Given this list of marker genes RNF145, CREBL2, SIX3, NEDD9, RORA, HMGCS1, ESR1, MAP3K1, CDK19, GPR158, KCNJ2, MBOAT2, PDE4D, CCDC88A, MAP7D1, TNFAIP3, ZCCHC3, PATJ, PHC3, TBPL1, PRSS12, TRPC4, HIF1A, PNLIPRP3, ZFP62, DIP2C, BBX, DIRAS2, RAB5A, PTGFRN, AGFG1, ADD3, EPB41L1, PARD6B, NEDD4, YPEL5, LACTB2, GLRB, TMEM170B, ZBTB20, PSD3, MEF2C, DPPA3, PHF19, NUFIP2, ESCO2, HEATR5A, ZBTB4, ATL2, PIAS3, ZNF367, KCNH7, IQSEC3, SH3BP4, FER, MAPK4, VPS13A, FCHSD2, ZNF365, HSF5, TWF1, GCLC, YBX3, ERI1, IRF2, RAB5C, TAOK1, KLHL20, ZCCHC24, NAA50, FAM3C, TRAPPC8, FRYL, ATM, KCMF1, BTG3, PDZD2, PTCHD1, XYLT1, TGFBR3, MYLK, TRIB2, TRIOBP, FAM9B, ZBTB47, ATXN1, RBBP8, TOR1B, GIGYF1, AEBP2, RUNX1, CCN2, XYLT2, ITGA2, KCNS2, FRS2, KCNA1, NR1I2, KPNA6, FBXL3, SMAD2, RABGAP1, TMEM248, GOSR2, KDM2A, HMBOX1, OLFML2B, PNISR, SUCO, CCR2, DICER1, SORBS2, CEMIP2, CA12, here is a description of the gene set: from publication Chen Y, Wang X (PMID 31504780) Genes predicted to be targets of miRBase v22 microRNA hsa-miR-4735-3p in miRDB v6.0 with MirTarget v4 prediction scores > 80 (high confidence targets). species: Homo sapiens Human Gene Set: MIR4735_3P